Given this list of marker genes OPRM1, CHRM1, CHRM2, HRH4, CHRM4, CHRM3, CHRM5, HRH3, here is a description of the gene set: Human Gene Set: GOBP_ADENYLATE_CYCLASE_INHIBITING_G_PROTEIN_COUPLED_ACETYLCHOLINE_RECEPTOR_SIGNALING_PATHWAY An adenylate cyclase-inhibiting G protein-coupled receptor signaling pathway initiated by acetylcholine binding to its receptor, and ending with the regulation of a downstream cellular process. species: Homo sapiens